Given this list of marker genes PRR12, ATP6V0A2, HRAS, SPECC1L, MTOR, GPR101, PGM2L1, OTUD5, VPS33A, ZFX (zinc finger protein X-linked), CDK10, LTBP1, ATP6V1B2, MTX2, RBM10, RNU4-2, KCNN3, ASXL2, DPYD, MAP2K1, AIP, TBL1XR1, HNRNPK, ASXL3, PIGA, ASXL1, SLC25A24, SPRED2, MAP2K2, KRAS, BRAF, SHOC2, KCNH1, here is a description of the gene set: Human Gene Set: HP_DEEP_PALMAR_CREASE Excessively deep creases of the palm. studied in species Homo sapiens Deep palmar crease